Given this list of marker genes TUT4, ATOSA, MDM4, RASGEF1B, FTX, RSRP1, PCSK7, RBM6, BIRC3, CLEC2D, PPP3CA, ANKRD11, B4GALT1, BPTF, ATF7IP, ATRX, CDK13, CTNNB1, LNPEP, SFPQ, ADAM19, CCNL1, C1orf56, STX7, ARGLU1, PSMA3-AS1, ARID1B, ASH1L, XIST, PARP14, NEAT1, ITSN2, SET, NKTR, TNRC6B, ZNF292, TTN, MBNL1, KMT2A, ATM, HNRNPH1 (heterogeneous nuclear ribonucleoprotein H1), CDC42SE1, IKZF3, CD22, SYNE2, GOLGB1, SEL1L3, BDP1, OGA, PRDM2, here is a description of the gene set: Human Gene Set: GAVISH_3CA_METAPROGRAM_B_CELLS_B_CELLS_1 In this study, an extensive analysis was conducted to define meta-programs (MPs) capturing intra-tumor heterogeneity across a spectrum of tumor types. The approach utilized non-negative matrix factorization (NMF) to analyze each cell type separately within individual tumor samples. This involved the analysis of malignant cells, macrophages, fibroblasts, endothelial cells, epithelial cells, T-cells, and B-cells. NMF was executed with varying parameter values (K=4, 5, 6, 7, 8, 9), thereby generating 39 programs for each cell type per sample. Each NMF program was summarized by the top genes based on NMF coefficients.\nRobust MPs were then delineated for each cell type using a set of stringent criteria, including recurrence within the same tumor, similarity to programs in other tumors, and non-redundancy within a tumor. Subsequently, these robust NMF programs were clustered (per cell type) based on Jaccard similarity, leading to the identification of MPs associated with each cell type.\nTo enhance the quality of the MPs, a refinement steps were undertaken, involving the removal of MPs suspected of reflecting low-quality data (with an overrepresentation of ribosomal proteins or mitochondrial-encoded genes), single-study inclusion, or similarity to miss-annotated cell types. Genes upregulated in subsets of cells of a given type within various tumors studied in species Homo sapiens from publication Gavish A, Tyler M, Greenwald AC, Hoefflin R, Simkin D, Tschernichovsky R, Galili Darnell N, Somech E, Barbolin C, Antman T, Kovarsky D, Barrett T, Gonzalez Castro LN, Halder D, Chanoch-Myers R, Laffy J, Mints M, Wider A, Tal R, Spitzer A, Hara T, Raitses-Gurevich M, Stossel C, Golan T, Tirosh A, Suvà ML, Puram SV, Tirosh I (PMID 37258682)